Given this list of marker genes TET1, LEF1, PLPP5, IFNGR2, MIR93, SCML4, EPHX1, MAP4K4, STT3B, TOX, MGST2, ALS2CL, SMCHD1 (NCBI Gene Id 2490), TSPAN32, ITGA6, IFT80, AGFG1, ART4, CCR9, TFDP2, DKC1, RGS10, TRAT1, METTL9, DDC, MTR, SELE, SH3BP5, ADGRG5, ST6GAL1, PLEKHG2, SSBP2, PTK2, CRIPTO, USP28, KCNA3, LBH, TRPM7, NAB2, CD2AP, BEND5 (NCBI Gene Id 79656), CEP97, DPP4, DAPL1, OSBP2, NEK8, AMOTL1, FNBP4, SLC35G1, SEC63, IPCEF1, KIFC2, ARHGDIG, NSG2, TMEM184C, FBXO46, ID3, GGT1, INSR, TGFBR1, TGFBR3, FAM193B, ACTN1, ABCE1, TMEM86B, RNF213, HDAC2, RAI1, TPCN1, RIMS4, RGL2, SCRN2, HDAC7, MYC, SEMA4B, ATP6V1D, CLDN6, UTP25, SLC28A2 (NCBI Gene Id 9153), PIK3C2A, PTH2R, SBNO1, AP1AR, ARFGAP1, RNF207, PLEKHA1, RAPGEF6, RREB1, TNIK, PATJ, KLF13, SESN1, CCR7, RAB3IP, BRWD1, FNTB, MX2, ECM2, EML5, TNKS, CBFB, AMPD1, TANC1, SLC25A42, WDR13, ABCA1, CACNB2 (NCBI Gene Id 783), APPL2, GRIA3, RAPGEF4, ITGAE, LDLRAP1, ACKR2, ADGRL2, TNRC6C, SELL, LDHB, PIK3R6, SFMBT2, NLRC4, STAT1, RALGPS2 (NCBI Gene Id 55103), GBP4, WNT16, SMAD1, VPS13C, NIPAL1, IGFBP4, IL6ST, SREBF2, IL3RA, MCOLN3, SLC49A4, SPACA1, GGT5, IZUMO1R, ADCY6, RBM38, ADGRL1, SLC4A3, ATRN, XKRX, L3MBTL1, OAS2, TOM1L2, CRLF3, TNFRSF14, PELI1, SLC16A5, NEDD4L, SELENOP, QSER1, SH3PXD2A, PDK1, RFLNB, DISP2, CHST15, SLC6A19, TREML2, PMEPA1, KRTAP17-1, FAM78A, CHD4, TDRKH, INPP4B, PCDH17, TMEM131, SI, SLC12A7, HDAC4, PBX2, TNFSF8, here is a description of the gene set: The gene expression profile of peripheral Foxp3+ natural regulatory T cells isolated from Foxp3/EGFP bicistronic mice was compared to that of in vitro-induced regulatory T cells and to CD4+ conventional (Foxp3-) T cells. The role of the regulatory T cell transcription factor Foxp3 in shaping the transcriptosomes of natural and induced regulatory T cells was analyzed using mice expressing a mutant FOXP3-EGFP fusion protein (Foxp3deltaEGFP). We used gene expression microarrays to examine the transcriptional programs of natural and induced regulatory T cells and the function of Foxp3 in organizing the transcriptosomes of the respective cell type from publication Haribhai D, Lin W, Edwards B, Ziegelbauer J, Salzman NH, Carlson MR, Li SH, Simpson PM, Chatila TA, Williams CB (PMID 19265124) studied in species Homo sapiens Human Gene Set: GSE14415_ACT_TCONV_VS_ACT_NATURAL_TREG_UP Genes up-regulated in activated T lymphocytes: T conv versus natural T reg.